The following is a description of a gene set: studied in species Homo sapiens Human Gene Set: GSE38696_LIGHT_ZONE_VS_DARK_ZONE_BCELL_DN from publication Victora GD, Dominguez-Sola D, Holmes AB, Deroubaix S, Dalla-Favera R, Nussenzweig MC (PMID 22740445) Genes down-regulated in B lymphocytes: light zone versus dark zone. Microarrays of gene expression in mouse germinal center light zone and dark zone B cells sorted according to the expression of cell surface molecules CD83 and CXCR4 We used microarray data to identify genes differentially expressed by B cells in the light and dark zones of germinal centers from mouse skin-draining lymph nodes 12 days after subcutaneous immunization with NP-OVA in alum., and this is the list of marker genes: YARS2, SEPTIN10, ESPN, NPR2, NRP2, OPN1SW, CIDEB, CLDN15, MST1R, H19, TIFA, SF3B4, BLNK, PAPPA (pappalysin 1), PTGIS, MBNL3, FRMD4B, SPIRE2, NDRG1, PABIR1, CACNA1B, SPRED2, SLC4A4, SORD, STIP1, BHLHE40, CAPNS1, H2BC4, FAM135A, SERPINE2, CERS2, ELL (elongation factor for RNA polymerase II), NCAPD3, DEGS2, MED25, SHC3, COX8BP, HSD17B1, SIAH3, CLPS, GSTCD, PLA2R1, DHRS1, FA2H, PTP4A3, GPR108, OBSCN, GRM5, PLK3, KCNN3, RHBDF2, CD80, PPP2R1A, DKK2 (NCBI Gene Id 27123), PROM2, NANOS1, SPAG4 (sperm associated antigen 4), AP3D1, SEMA7A, CIITA, DOT1L, EMD, ZMIZ2, KIF7, CD24, BCDIN3D, KLF12 (KLF transcription factor 12), FAM72A, S1PR3, CRYGS, SSBP4, CD68, CDKN3, A3GALT2, MED15 (mediator complex subunit 15), INSYN2A, MYD88, ALDH1A1, EIF3L, WNK1, DENND4A, PIGZ, BEND3, MUC4, TREX1, PIEZO1, GP2, TRIB1, CYP24A1 (NCBI Gene Id 1591), MIR503, ATP6V1B1, HNF1A, B3GNT9, CRYGA, TMEM61, SLC25A10, EIF1AD, GAD2, DMXL2, CSMD3, LRRC46, PCDH11X, SLC17A4, UNK, SLC41A3, SPHK1, HCRT, JMJD6, STXBP6, PLD4, TMEM53, DIPK1B, HDHD3 (haloacid dehalogenase like hydrolase domain containing 3), NGLY1, SLC1A2, CTXN1, TEX101, NECTIN2, ALOX12B, KRTAP6-1, TRH, LGALS12, RPS6KB2, NAPSA, RBM27, PSMD14, ENPEP, CCDC80, COX10, RRH, RBFOX2, HSD17B7, SULT1E1, ACCS, CACNA1C, DST, FAM124B, CCL22, HS3ST1